The following is a description of a gene set: studied in species Homo sapiens Human Gene Set: REACTOME_TACHYKININ_RECEPTORS_BIND_TACHYKININS Tachykinin receptors bind tachykinins, and this is the list of marker genes: TAC3, TACR3, TAC1, TACR2 (tachykinin receptor 2), TACR1